The following is a description of a gene set: Thromboxane signalling through TP receptor studied in species Homo sapiens Human Gene Set: REACTOME_THROMBOXANE_SIGNALLING_THROUGH_TP_RECEPTOR, and this is the list of marker genes: GNA15, GNAQ, GNB2, GNA13, AAMP, GNG4, GNA11, GNB1, GNG5, GNG12, GNG7, GNA14 (NCBI Gene Id 9630), GNB3, GNGT1, GNG2, GNG10, GNG13, GNGT2, GNG11, TBXA2R, GNB4, GNG3, GNG8, GNB5